Given this list of marker genes PHOX2A, RNF7, SMAP2, RTP4, LONP2, HAUS5, APC, RAB11B, SMPD1, NUDT13, RCAN3, AP3M2, SSR3, REEP5, SLC35F6, JARID2, PRXL2C, BCL2, RDM1, HMGB2, VPS41, EDEM2, STAT4, LAT, FOXJ2, PATZ1, PCDHA12, RB1CC1, FBXO25, SLCO3A1, ARHGAP12, CARD10 (caspase recruitment domain family member 10), ECH1, PIP4P2, SLC17A9, CDKN2C, SMPD5, RCBTB1, EBPL, FECH, RALGPS2, SEMA4F, DAPP1, SELENON, OAZ2, HS3ST3B1, NINJ1, ARMCX4, MAP4, GYPC (glycophorin C (Gerbich blood group)), RAD21, USP25, C3orf70, ARIH1, CSF1, FAM32A, HNRNPDL, YY1, UBC, TBCEL, UBALD1, CDC37L1, TSC22D4, PLIN3, POU2F3, ATP6AP2, NRDE2, PTBP1, DNAJC5, CHURC1, IRF7, PLA2G10 (phospholipase A2 group X), FGL2, SSBP4, ME2, MED20, TEX9, AGFG2, CMTM6, NR1H3, HSPA2, CLTB, ACADVL, ABCB9, RNF138, PTGER4, SOX4, CAT, PIP5K1C, COG4, HMGB1, RPL13A, SPPL3, PIK3C3, SCD, PCSK7 (proprotein convertase subtilisin/kexin type 7), TAF8, PPP1CA, NAA30, GLRX, ABHD8, PCNX3, ZFYVE26, RPRD2, HLCS, TM2D2, PARP14, KLHDC3, ANKMY2, KIAA0319L, SELENOT, RBM43, SGK1 (serum/glucocorticoid regulated kinase 1), STK24, CCDC28A, LY75, FANCM, CRIPT, APOBEC1, CUTA, GPX2, TSPAN14, FAM3C, NECAP2, PPP2R2A, GSTM5, FAH, FOXO3, SLC44A1, SLC23A3, AP4M1, CD5L, ZMYND8, WSB1, CASD1, FAM117A, PPOX, ACOX1, SLBP, FGF22, MIS18A, UPF2, ZBTB18, ATM (NCBI Gene Id 8068), GRK4, THY1, PLIN2, ETS1, CD86, SAFB, RYBP, UBL5, GOT1, TUBGCP3, ALKBH4, MIA3, RSRP1, SAT1, MOV10, HCLS1, ATAD2B, TNFRSF11B, VOPP1, TPR, CSNK1A1 (NCBI Gene Id 55416), HABP4, ADRA1A, SLAIN2, USP7, TOX (NCBI Gene Id 9760), FBRS, TNFRSF14, MYO9B, ANGEL2, FMNL3, CPT1A, TLE1, HAUS3, RAP1B, GTPBP1, DGKZ, HECTD3, CHAF1B, UQCRHL, GDI1, NATD1, RNF114, MYH11, S100A6, SLC52A3, PHKA2, RPS11, NPR2, STRN3, USP19, MINK1, STARD4, DUSP19, CHIC2, B3GNTL1, here is a description of the gene set: from publication Ng SY, Yoshida T, Zhang J, Georgopoulos K (PMID 19345118) Genes up-regulated in lymphoid-primed multipotent progenitors: wildtype versus IKZF1 knockout. Regulation of lineage potential and transcriptional priming by Ikaros. New insight is provided into a bivalent regulation of lineage priming in the HSC and its lympho-myeloid restricted progeny the LMPP by the lymphoid lineage-determining factor Ikaros Whereas Ikaros is responsible for the activation of a cascade of lymphoid expression programs and for the establishment of lymphoid potential from the HSC to the LMPP it is also responsible for the repression of stem cell and erythroid genetic programs that are incompatible with further lineage restrictions emanating from the LMPP species: Homo sapiens Human Gene Set: GSE15330_WT_VS_IKAROS_KO_LYMPHOID_MULTIPOTENT_PROGENITOR_UP